The following is a description of a gene set: species: Homo sapiens Human Gene Set: GOBP_ICOSANOID_TRANSPORT The directed movement of icosanoids into, out of or within a cell, or between cells, by means of some agent such as a transporter or pore. Icosanoids are unsaturated C20 fatty acids and skeletally related compounds., and this is the list of marker genes: ACE, SLC22A6, DRD3, PNPLA8, SLC22A8, ABCC11, CYP4A11, ABCC3, PLA2G12B, PLA2G1B, TNFSF11 (TNF superfamily member 11), PLA2R1, PLA2G2D, PLA2G2E, PLA2G4F, OXT, SLC22A2, PROCA1, OC90, SYK, P2RX4, ABCC6, IL1B, SLC22A7, NOS2, MIF, SLCO2A1, PLA2G2C, SLCO3A1, NMUR2, SLCO4A1, PLA2G12A, P2RX7, PLA2G5, ABCC4, PLA2G3, EDN1, SLCO1B1, SLCO2B1, SLC22A1, PLA2G2F, AVPR1B, ANXA1, PLA2G10, PTGES, LEP, ABCC1, SLC22A11, PLA2G4A, CYP4F2, TNFRSF11A, PLA2G2A, ACSL4, DRD2, BDKRB2, NTSR1, ABCC10, DRD4, NMB, ABCC2, PTGS2